Given this list of marker genes AQP2, AVPR2 (arginine vasopressin receptor 2), ARNT2, SLC12A1, NPHP1, KCNJ1, CLDN16, CLCN5, UMOD, here is a description of the gene set: Human Gene Set: HP_HYPOSTHENURIA Hyposthenuria studied in species Homo sapiens An abnormally low urinary specific gravity, i.e., reduced concentration of solutes in the urine.